The following is a description of a gene set: Mouse Gene Set: REACTOME_WNT5A_DEPENDENT_INTERNALIZATION_OF_FZD4 WNT5A-dependent internalization of FZD4 species: Mus musculus, and this is the list of marker genes: Cltb, Fzd4, Ap2b1, Cltc, Ap2a2, Dvl2, Clta, Ap2s1, Prkcb, Ap2m1, Wnt5a, Ap2a1, Prkcg, Arrb2